Given this list of marker genes SEPHS2, MFSD14B, CBS, TCEA1, SCG2, ABCF2, CLMN, ENTPD6, CDY1B, MBNL2, ADARB1, PGC, STAT6, MSR1, MTCL2, PUM2, RAPGEF4, FSD1L, NEMP2, GARIN1B (NCBI Gene Id 84691), SRGAP1 (NCBI Gene Id 57522), RBM20, ESF1, LRP5L, RBMS3, DENND2D, TASOR, PLXDC2, RPUSD3, ZFP36L2, PIK3CA, OTX2, OTX1, FGFRL1, SLU7, TCF21, AMOTL2, RGS12, PTEN, HMGA1, PRSS16, CHD1, RYR2, SLITRK5, EI24, RAB11A, NOX1, RETREG1, IL10RA, CDY1, HSD17B13, CNR1, S1PR3, ZFHX4, RYR3, SLC6A2, KDM5C, CTBP2, ENSG00000274276, VBP1 (VHL binding protein 1), ZFP62, POU3F3, NRIP1, TNC, STAC2, SPATA6, TRIM60, CEP350, RPL41, TNFSF4, RFX2, MAPK12, ADAM28, TXNDC9, METAP2, RPAP2, SNCAIP, APH1A, FUT8, H3-3A, SAR1A, DDR2, TMOD2, FGF11, ATG12, ZNF362, RAD51, ADGRB3, COA6, PBX1, KCNH4, here is a description of the gene set: from publication Chen Y, Wang X (PMID 31504780) Human Gene Set: MIR198 species: Homo sapiens Genes predicted to be targets of miRBase v22 microRNA hsa-miR-198 in miRDB v6.0 with MirTarget v4 prediction scores > 80 (high confidence targets).